The following is a description of a gene set: electronically inferred by orthology from the curated human pathway Reactome Pathway: TP53 Regulates Transcription of Death Receptors and Ligands species: Mus musculus This event has been computationally inferred from an event that has been demonstrated in another species.<p>The inference is based on the homology mapping from PANTHER. Briefly, reactions for which all involved PhysicalEntities (in input, output and catalyst) have a mapped orthologue/paralogue (for complexes at least 75% of components must have a mapping) are inferred to the other species. part of: TP53 Regulates Transcription of Cell Death Genes, and this is the list of marker genes: Igfbp3